The following is a description of a gene set: A deviation from the normal concentration of haptoglobin in the blood circulation. species: Homo sapiens Abnormal circulating haptoglobin concentration Human Gene Set: HP_ABNORMAL_CIRCULATING_HAPTOGLOBIN_CONCENTRATION, and this is the list of marker genes: RNF31, UROS, RHCE, C1GALT1C1, XK, PIGA, KIF23, CBLIF, ABCG8, GATA1, PKLR, SLC2A1, RHAG, RHD, KLF1, ALDOA